Given this list of marker genes Zfp148, Nudt4, Dlc1, Cggbp1, Taf6, Kdm4c, Fat1, Slc25a12, Atp13a3, Rab5a, Gskip, Sox8 (NCBI Gene Id 20681), Cmip, Ror2, Ormdl3, Zzef1, Ankrd12, Stag2, Pim3, Wdr90, Fadd, Fam76a (NCBI Gene Id 230789), C3ar1, Sipa1l2, Phactr4, Trrap, Ccna2, Paip1, Clasp1, Nr1h5, Tm9sf3, Stag1, Mef2d, Ptprt, Fermt2, Cacna2d2, Sox9, Tbx20, Srebf1, Golm2, Entpd6, Tbc1d10b, Tsc22d2, Abhd17b, Zeb2, Rbm5, Jakmip3, Rasgrp2 (NCBI Gene Id 386467), Gnrhr, Ksr2, Rbms3 (RNA binding motif, single stranded interacting protein), Gabrb2, Srsf3 (NCBI Gene Id 20383), Lmx1a, Snx25, Cdk17, Med13, Ppp1r3d, Gpc4, Itsn2, Bcor, Nol4l (nucleolar protein 4-like), Sertad2, Creb3l1, Mtmr3, Nos2, H2az1, Usp21, Tshz1, Sox2 (NCBI Gene Id 20674), Phaf1, Ddost, Zfr, Hivep2, Clk4, Prex1, Ccng2, App, Cntn1, Pdhx, Fubp1, Chn2, Mbtd1, Pdpk1, Thoc2, Septin2, Lrrtm3, Smarcd2, Zmynd19, Atp6v1b2, Atp5f1a, Krit1 (KRIT1, ankyrin repeat containing), Kdelr1, Rnps1, Sp5, Cdkn2d, Cstdc2, Pcdh20, Srpx, Snx2, Gmcl1, Neurod6, Trim2, Zyg11b, Kif13a, Pum2, Gphn, Pias1, Derl1, Prrc2c, Csnk1g2, Phip, Zcchc8, Tnfsf11, Zfp385b, Sdr16c6, Galnt2, Fbxo11, Rab7, Csmd1, Nr2c2, Cltc, Casz1, Dock1, Ebf2, Slc38a2, Spry2, Gsk3a, Dido1, Bcas1, Ggnbp2 (NCBI Gene Id 97681), Spryd3, Gdap2, Tcf7l2, Slc10a7, Tob2, Sox11, Tpm1, Epb41l3, Jph1, Pum1, Eif4enif1, Pfn2, Lrch3, Rapgef6 (Rap guanine nucleotide exchange factor (GEF) 6), Fmnl2, Rora, Adam10, Pde9a, Zfhx3, Rpain, Asxl2, Hs3st3b1, Brix1, Pik3r1, Sh2d3c, Tm2d3, Rasal2, Atp6v1g1 (NCBI Gene Id 98834), Nxph2, Bmi1, Golga5, Smoc1, Adamtsl3, Erbb2, Abca6, Slitrk4, Nedd1, Cntn4, Ppp1r16b, Pdgfc, Slitrk5, Srpk2, Smarce1, Mill1, Arnt, Lsm8, Wac (NCBI Gene Id 76331), Wdr48, Snrpd1, Ckap5, Tbc1d12, Zfx (zinc finger protein X-linked), Glipr1l2, Znhit3, Fzd7, Foxc1 (NCBI Gene Id 17300), Cul4b, Csmd2, Kdm5b, Dcx, G3bp2, Ino80, Abcc5, Map1b, Selenos, Dab2ip, Col13a1 (NCBI Gene Id 12817), Ppip5k1 (NCBI Gene Id 327655), Scamp2, Pald1, Sdc3, Npas2, Gtpbp2, Nap1l4, Erbin (NCBI Gene Id 72261), Nelfa, Pja1, Ncoa1, 4921517D22Rik, Stk24, Dennd4a, Cdyl, Tmem106b, Ccn2, Hlf, Cited2, Hycc2, Usp2, Unk, Cnksr2, Ppp1r8, Herc4, Grb7, Kat8, Ankrd49, Cacul1, Wdfy1, Lrrn2, Rrp15, Rab14, Leo1, Nrxn3, Mtss2, Apc, Wdr47, Celf4, Ovol1, Hmgb2, Eomes, P2ry1, Lhx1, Bmpr2, Tctn1, Eya1, Smad2, Elfn1, Hivep1, Cdc42bpa, Arhgef17, Arhgef7, Rbm47 (RNA binding motif protein 47), Tmem185a, Fut9, Srf, Adamtsl1, Mastl, Arfgef1, Ppp2ca, Rfx7, Taok1, Jade1, Rab19 (NCBI Gene Id 19331), Nampt, Mllt3, Tmem19, Cadm1, Asxl1, Cemip2, Nedd9, Fbxw11, Rspo2, Pkp4, Usp42, Fnip1, Ptk2, Ubqln2, Lca5, Skil, Il1r1, Col11a1, Ccdc6, Bcl2l11, Tubb4b, Igip, E2f4, Cxcr4, Rbbp6, Nmd3 (NMD3 ribosome export adaptor), Ppp2r5c, Heatr1, Cend1, Dip2a, Kif3a, Neo1, Fubp3, Adnp, Pcdh11x, Casd1, Pcdh7, Lrp5, Lrp6, Ptk2b, Sox1, Actc1, Tmem47, Arpc5l, Lrig1, Atp2a2, Dctn6, Hic2, Ppp2r5d, Ppp1r2, Sdad1, Ubqln1, Ptprj, R3hdm1, Tmem170b, Glis3, Trio, Iws1, Neurod1, Slc22a23, Cops7b, Xkr4, Ralgps1, Sorbs2, Kdm6a, Zfp516, Ssu72, Lmtk2, Pou3f4, Gad1, Taf5, Galnt12, Ift70b, Sh3gl2, Tm7sf3, Tbl1xr1, Rab2a, Phf6, Rpa2, Synj2bp (NCBI Gene Id 28115), Cyria, Cacna2d1, Ripor2, Sobp, Neurl1b, Ppp1ca, Cxxc4, Hmgcs1, Zfand5, Crispld1, Kcnc2, Zfhx4, Zfp362, Brd8, Gpatch1, Snip1, Nckap5, Lrrc4 (leucine rich repeat containing 4), Tlk1, Gls, Rab40c, Ptprc, Tanc2, Arid4b, Btg1, Clec10a, Ap2b1, Rtn4rl1, Tab2, Wdfy3, here is a description of the gene set: Genes predicted to be targets of miRBase v22 microRNA mmu_let_7g_3p in miRDB v6.0 with MirTarget v4 prediction scores > 80 (high confidence targets). from publication Chen Y, Wang X (PMID 31504780) studied in species Mus musculus Mouse Gene Set: LET_7G_3P